The following is a description of a gene set: species: Mus musculus Genes up-regulated in MEF cells (embryonic fibroblast) expressing ~25% of YY1. from publication Affar el B, Gay F, Shi Y, Liu H, Huarte M, Wu S, Collins T, Li E, Shi Y (PMID 16611997) Constitutive ablation of the Yin Yang 1 (YY1) transcription factor in mice results in peri-implantation lethality. In this study, we used homologous recombination to generate knockout mice carrying yy1 alleles expressing various amounts of YY1. Phenotypic analysis of yy1 mutant embryos expressing approximately 75%, approximately 50%, and approximately 25% of the normal complement of YY1 identified a dosage-dependent requirement for YY1 during late embryogenesis. Indeed, reduction of YY1 levels impairs embryonic growth and viability in a dose-dependent manner. Analysis of the corresponding mouse embryonic fibroblast cells also revealed a tight correlation between YY1 dosage and cell proliferation, with a complete ablation of YY1 inducing cytokinesis failure and cell cycle arrest. Consistently, RNA interference-mediated inhibition of YY1 in HeLa cells prevents cytokinesis, causes proliferative arrest, and increases cellular sensitivity to various apoptotic agents. Genome-wide expression profiling identified a plethora of YY1 target genes that have been implicated in cell growth, proliferation, cytokinesis, apoptosis, development, and differentiation, suggesting that YY1 coordinates multiple essential biological processes through a complex transcriptional network. These data not only shed new light on the molecular basis for YY1 developmental roles and cellular functions, but also provide insight into the general mechanisms controlling eukaryotic cell proliferation, apoptosis, and differentiation. Human Gene Set: AFFAR_YY1_TARGETS_UP, and this is the list of marker genes: KDR, MYH3, UBC, LAMB2, SIN3A, BMP4, NAP1L3, WT1, BTG2, WNT16, MYL11, TXNIP, PROX1, POLK, ABCA1, CLU, PAFAH2 (platelet activating factor acetylhydrolase 2), SYCP3, ALCAM, ATP6V0E2, PTP4A3, MYOM1, MYCN, DMPK, LDHB, ELOVL2, SELENOP, STX3 (NCBI Gene Id 6809), EBF2, RBMX, GBP6 (guanylate binding protein family member 6), NEUROD6, KIF5B, TSLP, PLCB4, SRC, SLC2A4, FYB1, CDKN1A, MS4A1, GPR137B, CFH, GRIA3, RND3, LDB3, IL17D, NHERF2, TNFRSF10B, TTLL1, PERP, NGFR, S1PR5, NDUFA7, CTNND2, LPIN1, TNNI1, SLC27A3, DCXR, NPTX2, MYO1C, MYH7, RNF41, ITGB6, MYH1, CEND1, TAP1, USP20, ABCC5, TCFL5, SLC12A5, CHODL, PBX4, RAMP2, DSTYK, TP53INP1, ZNF3 (zinc finger protein 3), PFKFB2, ZNF385A, MAP6, PMM1, ACTC1, LGALS9, HHIP, ABCD4, SPAG1, PLOD2, JAK3, EHD1, CEACAM21, PSRC1, BEX1, FXYD6, COL10A1, ANXA8L1, RPGRIP1, EPHA2, CFTR, MPG, TGM2, MAL, SNRPN, B4GALT4 (beta-1,4-galactosyltransferase 4), HM13, PRSS35, BMP6, KLRB1, TPD52L1, PPP1R15A, AJUBA, SLC6A14, ABAT, ST6GALNAC3, FLT1, ADAM15, TNNC2, CELF4, BCL2L1, PMAIP1, FOS, PLCZ1, SNURF (SNRPN upstream open reading frame), NNAT, HSD17B1, LRP2, CDO1, HACL1 (NCBI Gene Id 26061), ICAM1, SERPINB3, BDNF, RORC, SH2D1A, GPC3, MMP2, SLC2A3, DUSP1, PEX19, UNCX, KRT19, SULF2, MYL1, PDLIM3, H2AC18, GBP2, ABCA3, TBX2, GFER, FABP3, ARR3, STK25 (serine/threonine kinase 25), KLK8, SLC1A6, CTSF, CPEB1, BAK1, BLCAP, MASP1, PAWR, H1-2, CDKN1C, SOX2, DRD4 (NCBI Gene Id 1815), EGFR (NCBI Gene Id 1956), CASP7, SURF1, EPHA7, SPOCK3, COL19A1, SFN, ANKRD1, TGFB2, CRYAB, FAM9A, TPM1, EFEMP1, PLTP, ITGA9, NRG3, GADD45G, TPH1, TSSK2, ID4, TNNC1, EHF, ACKR3, UCHL1, H2BC4, TINAGL1, HEMGN, CBLN1, SIM1, IRAG1, MDM2, NTF3, HSF2, SELENOM, FJX1, MYH2 (NCBI Gene Id 4620), KIF17, ACOX1, SYT11, FAS